Given this list of marker genes CHRNE, SLC6A7, SLC34A1, TTR, SLC6A4, SLC10A1, SLC12A1, SLC15A1, SLC17A2, SLC17A3, SLC6A3, SLC16A2, SLC12A3, SLC6A1, SLC16A4 (NCBI Gene Id 9122), SLC16A6, SLC10A2, SLC16A8, here is a description of the gene set: Human Gene Set: MODULE_368 Peptide and AA transporters. studied in species Homo sapiens